The following is a description of a gene set: Human Gene Set: WP_CELLS_AND_MOLECULES_INVOLVED_IN_LOCAL_ACUTE_INFLAMMATORY_RESPONSE studied in species Homo sapiens Cells and molecules involved in local acute inflammatory response, and this is the list of marker genes: VCAM1, IL6, IL1A, ICAM1, C7, SELP, TNF, ITGAL, C5 (NCBI Gene Id 727), SELPLG, ITGB1, KNG1, CXCL8, ITGB2, ITGA4, C6, C3